The following is a description of a gene set: Genes with high-CpG-density promoters (HCP) bearing the bivalent histone H3 trimethylation mark at K4 and K27 (H3K4me3 and H3K27me3) in neural progenitor cells (NPC). We report the application of single-molecule-based sequencing technology for high-throughput profiling of histone modifications in mammalian cells. By obtaining over four billion bases of sequence from chromatin immunoprecipitated DNA, we generated genome-wide chromatin-state maps of mouse embryonic stem cells, neural progenitor cells and embryonic fibroblasts. We find that lysine 4 and lysine 27 trimethylation effectively discriminates genes that are expressed, poised for expression, or stably repressed, and therefore reflect cell state and lineage potential. Lysine 36 trimethylation marks primary coding and non-coding transcripts, facilitating gene annotation. Trimethylation of lysine 9 and lysine 20 is detected at satellite, telomeric and active long-terminal repeats, and can spread into proximal unique sequences. Lysine 4 and lysine 9 trimethylation marks imprinting control regions. Finally, we show that chromatin state can be read in an allele-specific manner by using single nucleotide polymorphisms. This study provides a framework for the application of comprehensive chromatin profiling towards characterization of diverse mammalian cell populations. species: Mus musculus from publication Mikkelsen TS, Ku M, Jaffe DB, Issac B, Lieberman E, Giannoukos G, Alvarez P, Brockman W, Kim TK, Koche RP, Lee W, Mendenhall E, O'Donovan A, Presser A, Russ C, Xie X, Meissner A, Wernig M, Jaenisch R, Nusbaum C, Lander ES, Bernstein BE (PMID 17603471) Mouse Gene Set: MIKKELSEN_NPC_HCP_WITH_H3K4ME3_AND_H3K27ME3, and this is the list of marker genes: Tuba4a, Ahnak (AHNAK nucleoprotein), Gprc5c, Dll4 (NCBI Gene Id 54485), Kcnc4, Foxq1, Sema7a, Ccdc85a, Gdnf, Fli1, St8sia2, Celsr3, Emb, Adamts2, Pth2, Foxb1, Mapk8ip2, Slc40a1, P4ha2, Acan, Foxf2, Ascl2, Sox1, Adora2b, Hoxc4, Hmx1, Oaf, Kndc1, Fgf5, Myrip, Aff3, Tub, Fgf15, Ntng1, Kcnk12, Insm2, Rgs9bp, Nxph3, Plag1, Cdkn1a, Sntb1, Arg2, Gpat3, Erbb3, Pltp, Cdh11, Wnt9a, Bmi1, Gchfr, Ptpru, Nrarp, Tmem181a, Disp3, Ap3b2, Kcnk1, Ngfr, Map3k9, Nog, Neurog1, Gata6, Ablim2, Slc35d3, Paqr9, Kcnma1, Shh, Foxf1, Mnx1, Bhlhe22, Vgf, Gpc5 (NCBI Gene Id 239259), Hoxc5, Cbln1, Ak5, Hrk, Lama1, Flt1, Baiap2l1, Six2, Csmd1, Gpr88, Foxd4, Adora1, Col27a1, Tenm4, Atp7b, Nmnat2, Tfap2a, Rab20, Rasgef1b, Gnal, Frmd5, Sfi1, Spire2, Gad1, Wnt6, Plekhg3, Igf2bp2, Hoxd13, Coch, Prdm6, Chst8 (NCBI Gene Id 68947), Esrrb, Pcsk2, Ptgfrn, Bik, Elfn1 (NCBI Gene Id 243312), Bmf, Pcdh8 (protocadherin 8), Kcna3, Kdelr3, Kcna1, Trnp1, Slc24a4, Psmb9, Hoxd1, Rgs6, Efcc1, Rspo2, Wnt11, Fgf9 (fibroblast growth factor 9), Xkr5, Cdk5r2, Stk32c, Unc5a, Podn, Ndrg1, Zfp296, Bicdl1, Wnk2, Gja3, Ina, Nxph4, Cdhr1, Hmx2, Cds1, Ptger4, Ccno, Tspan18, Ret, Tacr1, Jph1, Galnt14, Fbxo43, Slc26a4, A4galt, Egr4, Slc24a2, Ptger3, Ica1l, Tead4, Crh, Gch1, Reln, Nefm, Tgfb1, Adra2b, Amer3, Cxcr4, Synm, Egflam, Plxna4, Kcnh3, Kif5c, Smoc2, C2cd4b, Stx3, Nefl, Prmt8, Satb1, Smad6, Bmp8a, Gng8, Cpeb1, Ocln, Itga3, Mmp24, Chrna5, Vstm2b, Rassf5, Ptpn5, Adrb3, Gpr45, Cdh22, Neurog2, Nppc, Camkk1, Foxc2, Tmtc4, Rasgrf1, Msx2 (msh homeobox 2), Casz1, Cldn23, Fam78a, Gabra4 (gamma-aminobutyric acid type A receptor subunit alpha 4), D430041D05Rik, Slc30a10, Slc35f2, Atoh1, Sh3rf3, Slc6a15, Kcnj4, Adamts8, Klhdc8a (kelch domain containing 8A), Eomes, Ptprn2, Ankrd33b, Hs3st3a1, Cxcl12, Mfsd4a, Fgf11